The following is a description of a gene set: Human Gene Set: GSE18893_CTRL_VS_TNF_TREATED_TREG_24H_UP studied in species Homo sapiens Here we show that tumor necrosis factor (TNF) induced in human T-regulatory cells (Treg), as compared to conventional T cells (Tcon), a transcription program highly enriched for typical NF-κB target genes, such as: the cytokines LTA and TNF; the TNF-receptor super family members FAS, 4-1BB and OX-40; various anti-apoptotic genes; and other important immune-response genes. As an initial approach to examine the cellular program induced by TNF in Tregs versus Tcon cells, we employed microarray gene expression analysis at 2 and 24 hrs following TNF treatment. Genes up-regulated in T reg cells: 2h versus 24h medium treatment. from publication Nagar M, Jacob-Hirsch J, Vernitsky H, Berkun Y, Ben-Horin S, Amariglio N, Bank I, Kloog Y, Rechavi G, Goldstein I (PMID 20181891), and this is the list of marker genes: JPT2, TNFRSF1A, PNPO, CAMKK2, ZNF512B, RHBDD3, SLC10A6, PXN, RPRD1A, HNRNPC, MPZL2, CCDC191, CENPW, NDEL1, GCH1, ABCG1, MAPK1IP1L, OLR1, CARD10, ABHD10, DUSP5, ATP13A3, TBC1D10B, SC5D, PEX1, FRMPD3, STYXL1, ELOVL6, DUSP16, GLYCTK, CA10, OXT, GYS1, TES, NLRC3, RAF1, ASB9, CASQ1, C1orf43, C16orf86, ARF4, RPIA, UCHL1, ACVR2B, UBE2N, SCHIP1 (schwannomin interacting protein 1), EREG (NCBI Gene Id 2069), FAM117A (family with sequence similarity 117 member A), LIMS2, SLC7A4, CAMKMT, MMEL1, KRT71, COL4A2, MOCOS, IRAK2, RTN4RL1, SOHLH1, SEC22C, RAP2C, HMGA2, MLX, PTPRC, ETHE1, THADA, ITPRIPL2, ESYT1, MDM2, CMTR1, FAM167A, GPR150, SOCS4, GYPC, PCED1B (PC-esterase domain containing 1B), ROPN1L, HLA-B, TMEM127 (NCBI Gene Id 84178), BICRAL, COL6A3, CRISPLD1, FGD6, HRG (NCBI Gene Id 3273), SLC30A1, ADCY5, CWC25, MRPS12, IP6K2, MED10, HOXA2, SAMD9L (sterile alpha motif domain containing 9 like), SPTBN2, OSMR, IL18R1, NDST1, ZNF628 (zinc finger protein 628), BAZ1B, PODN, LMO3, SCFD2, ZNF823, CAMP, SSR3, SLC25A28, ZDHHC18, ITPK1, CD300A, DHCR7, GGT1, FOXM1, AP3D1, DDC, MYCBPAP, RABGEF1, SLC13A2 (NCBI Gene Id 9058), PATL2, SLC23A3, LIMD2, AP3M1, INS, SNX27, EPOR, IL17B, TMPRSS6, KRT72, SH3PXD2B, STAC3, DHX29, STK4, KRT36, HGF, MTCL1, IDI1 (NCBI Gene Id 3422), IFT74, BLTP1, BMAL2, NOXO1, ID2, MCU, SFXN2, FAM156A, DOC2B, CCDC120 (NCBI Gene Id 90060), EP400, CDKN2AIPNL, IFIT1, TNKS2, TMEM170B, SLFN12, TULP1, CA5B, MTERF1, LCE3B, DDR1, MFN2, RFLNA, EHD4, CES1, PSMB9 (proteasome 20S subunit beta 9), TRAPPC14, CEP19, LPGAT1, FDFT1, SIK1, PAPPA2, ARHGAP18, RFX5, C2CD4B, FHIP1A, STRN4, NIBAN2, SLFN12L, TBP, MIXL1, HILPDA, HYOU1, TMEM86B, CSTB, SCTR, CRISPLD2, NIPSNAP3A, SRXN1, RGS8, HDC, ZW10, PROK2, SPRY1, ANP32E, MYPOP, OGDH, CDH16, PBK, EPHX1, ZSWIM5, ADORA2A, FAM110C, ADNP2, HBS1L, BCL10, TBC1D2, PARP12